The following is a description of a gene set: species: Homo sapiens Human Gene Set: GOMF_L_PROLINE_TRANSMEMBRANE_TRANSPORTER_ACTIVITY Enables the transfer of L-proline from one side of a membrane to the other. L-proline is pyrrolidine-2-carboxylic acid., and this is the list of marker genes: SLC1A4, SLC36A1, SLC6A20, SLC36A2, SLC36A3, SLC36A4, SLC6A7